Given this list of marker genes FEN1 (flap structure-specific endonuclease 1), EXO1, APEX1, NYNRIN, RNASEH1 (NCBI Gene Id 246243), RNASEH2A, here is a description of the gene set: studied in species Homo sapiens Catalysis of the endonucleolytic cleavage of RNA in RNA-DNA hybrids to 5'-phosphomonoesters. Human Gene Set: GOMF_RNA_DNA_HYBRID_RIBONUCLEASE_ACTIVITY